The following is a description of a gene set: part of: SLC transporter disorders Reactome Pathway: Defective SLC22A18 causes lung cancer (LNCR) and embryonal rhabdomyosarcoma 1 (RMSE1) species: Homo sapiens The human gene SLC22A18 (aka TSSC5) encodes organic cation transporter-like protein 2 (ORCTL2). It is expressed at high levels in kidney, liver and colon and at lower levels in heart, brain and lung. ORCTL2 can transport organic cations such as chloroquine and quinidine with the antiport of protons.<br><br>The human chromosome region 11p15.5 is linked with Beckwith-Wiedemann syndrome (associated with susceptibility to Wilms' tumor, rhabdomyosarcoma and hepatoblastoma). SLC22A18 is located in this region. Mutations and/or reduced expression of SLC22A18 have been found in certain tumors such as lung cancer (LNCR; MIM:211980) and embryonal rhabdomyosarcoma 1 (RMSE1; MIM:268210). How SLC22A18 might be involved in growth regulation is poorly understood. There is speculation that it may be involved in resistance to chemotherapy drugs and/or in the export of genotoxic substances whose retention may increase the risk of tumor formation., and this is the list of marker genes: SLC67A1